The following is a description of a gene set: Cytokines mediate cell-cell communication in the immune system and represent important therapeutic targets. A myriad of studies have highlighted their central role in immune function, yet we lack a global view of the cellular responses of each immune cell type to each cytokine. To address this gap, the authors created the Immune Dictionary, a compendium of single-cell transcriptomic profiles of more than 17 immune cell types in response to each of 86 cytokines (>1,400 cytokine-cell type combinations) in mouse lymph nodes in vivo. A cytokine-centric view of the dictionary revealed that most cytokines induce highly cell-type-specific responses. For example, the inflammatory cytokine interleukin-1β induces distinct gene programmes in almost every cell type. A cell-type-centric view of the dictionary identified more than 66 cytokine-driven cellular polarization states across immune cell types, including previously uncharacterized states such as an interleukin-18-induced polyfunctional natural killer cell state. from publication Cui A, Huang T, Li S, Ma A, Pérez JL, Sander C, Keskin DB, Wu CJ, Fraenkel E, Hacohen N (PMID 38057668) Genes negatively differentially expressed in cell type: Macrophage upon treatment with cytokine: GM-CSF in mouse lymph nodes in vivo. Mouse Gene Set: CUI_MACROPHAGE_GM_CSF_RESPONSE_DN species: Mus musculus, and this is the list of marker genes: Syndig1l, Cox7a2l, Dhrs1, Epsti1, Gngt2, Rgs10, Sat1, Igkc, Tmem86a